The following is a description of a gene set: Pathway Definition from KEGG: NOTCH -- ADAM17 >> (PSEN+PSENEN+NCSTN+APH1) -> NICD species: Homo sapiens Notch proteolytic activation. Pathway ID: N01478. Pathway type: Reference. Pathway class: nt06511 NOTCH signaling. Human Gene Set: KEGG_MEDICUS_REFERENCE_NOTCH_PROTEOLYTIC_ACTIVATION, and this is the list of marker genes: PSEN2, PSEN1, NCSTN, NOTCH2, PSENEN, APH1A, NOTCH3, ADAM17, NOTCH1, NOTCH4, APH1B